The following is a description of a gene set: from publication Suryani S, Fulcher DA, Santner-Nanan B, Nanan R, Wong M, Shaw PJ, Gibson J, Williams A, Tangye SG (PMID 19965666) Human Gene Set: GSE17186_CD21LOW_VS_CD21HIGH_TRANSITIONAL_BCELL_UP Goals/objectives: to identify various gene expression in B cell subsets derived from human PBMC and cord blood species: Homo sapiens Genes up-regulated in transitional B lymphocytes: CR2 low versus CR2 high., and this is the list of marker genes: HLA-G, SLC12A9 (solute carrier family 12 member 9), ATAD2, SULF2, FUT7, TREX1, ARHGEF2, PTPA, CDYL2, PRDX4, SREBF2, MIS18BP1, CDC14A, TMEM120B, PARVG, CDC6, ACER3, POGLUT2, PIAS3, PAOX, WBP1, MCM8, EPS8, ZNF367 (zinc finger protein 367), FBXO42, CD72, BAZ1A, CNPY3, SERPINB1, LGMN, KRT80, AKT1, TSPOAP1, SLC35A5, TJP2, SLC29A1, N4BP3, GATM, LAMTOR1, TTC7A, USP12, RUFY1, ERCC6L, GAB2, IFT140, RASGRP3, GPC2, KCTD14, ESAM, STARD9, MAPK11 (mitogen-activated protein kinase 11), ASXL1, HNRNPLL, PPFIA4, SEPHS1, KIF20B, TYMS, CARMIL1, CCNE2, NDST1, SWAP70, GALNT1, METRNL, EEPD1, MAP4K5, CTC1, PRKCB, FILIP1L, B9D2, PTPRE, GPR155, CENPF, RNF149, LRP1, GCNT2, PEX16, PTPN6, NLRX1, NRROS, OAS2, AURKB, BRCA1, AURKA, CHKA, RAD51AP1 (RAD51 associated protein 1), RAP1GAP2, NEDD4, HTRA2, ANKH, FIGNL1, SYPL1, CENPP, TIAM1, EIF4E3, SPAG5 (sperm associated antigen 5), TNF, EFCAB14 (EF-hand calcium binding domain 14), RRAS, AARS1, PTPN3, ALDH16A1, CCSER1, BUB1B, SLFN5, STIMATE, ARHGAP39, TMEM131L, DHRS13, ELMO1, CXCL10, RFC2, SLC35C2, FEN1, TNFRSF13B, ACTG1, PRRC1, CDC42EP3 (NCBI Gene Id 10602), RCAN1, HERPUD1, ABL1, ESCO2, TMPO, CENPH, WDR86, PLSCR1, RBM47, SMC2, TUSC1, ATP7A, SMIM3, RBPJ, SASH1, HDAC9, TJP3 (NCBI Gene Id 27134), NCAPD2, CADM3, ZNF703, CSNK1E, NSMAF, PRKRA, EEA1, GEN1, EZH2, SLC6A12, EPB41L2, IFT57, GKAP1, ITPR1, UBE2G2, TUBB6, COMT, CACNA1S, CD180, TBC1D16, MAP3K14 (NCBI Gene Id 9020), HPS3, TASL, NCF4, IFI44, LRRC75A, FCHO2, PSRC1, ITGB2, NLRP3, INPPL1, C11orf54, AFDN, ASPM (NCBI Gene Id 93990), TSPAN31, LYST, LEPROT, PIMREG, RAD51D, COPG2, OAS1, CASS4, BEND4, KIF20A, LRP8, CHD9, CD81, TPX2, BIRC3, SLC4A8, OMA1, REM1, MAN1A1, PTK2, NDC80, TMEM35B, OAT, TTK, DHRS3, NELFE, IL3RA, CERS6, SAPCD2, RRBP1, APP, RAB31